Given this list of marker genes SLC4A3, RNF187, LY75, ESYT1, TFAP4 (NCBI Gene Id 7023), FIG4, VEGFA, TARS1, CASP9, CDC5L, TRIO, HLA-DPB1, TCHH, UQCRC2, ITGA3, PLEKHB1, TNFRSF25, TP53BP1, MAGEB2, FKBP1B, CARD10, AHCY, CYB5R3 (NCBI Gene Id 1727), PCNX2, MISP, ECE1, CNOT3, TFE3, CUL4A, SERINC5, HS3ST1, PRR4, ZC3H15, SLC7A5, RIPK2 (NCBI Gene Id 8767), SREBF1, KCNQ1, LPCAT1, DLGAP4, GNAQ, CCHCR1, IRF5, CDH5, CPSF4, ACOT7, ESR1, NACA, PGM1, RBL2 (RB transcriptional corepressor like 2), COX4I1, CDC25A, RBM4B, SOX9, PVALB, CPLX2, HTR1B, AMIGO2, ABCC10, SNU13, CBS, PABPC4, RRP1B, GARS1, YARS1, SUN2 (Sad1 and UNC84 domain containing 2), TM7SF2, KRT16, PCDHB11, HLX, KRT86, TBXAS1, TBX1, UBAC1, RUVBL2, NDUFAF3, TRAPPC12, FOXN3, PTPN9, XIAP, LSM14A, MSMB, EXD2, TK1, ALDH1A2, PPARG, ATG9A, AKAP8L, BDH1, IMPA2, IFT27, SNAPC5, CCK, FOLH1, F7, CCNH, RPS6KA2, SOCS1, SSTR5, ZFYVE26, SLC1A5, RAB33A, SPIDR (scaffold protein involved in DNA repair), ATXN2L, PTPRA, PLA2G5, ENTREP1, LTA4H, MYO1F, GSDME, GPR35, AIMP1, CXCR4, SIX6, ACP5 (NCBI Gene Id 54), TTC22, RNF44, TTC3, TJP1, ARHGEF18, MPST, MDM2, CALB2, DDX51, GRAMD4, TBC1D22A, BAAT, TNFRSF11A, MGAT1, IL5, SHB, CSTF2, CHST7, DCTN2, DCP2, AP1B1, IRF4, GRK2, EIF4H, FYN, UNC5B, BCR, ADH6, PYGL, GATA2, LYPD3, STOML2, PRKRA (NCBI Gene Id 94716), POU2F2, COQ9, DPY19L1, PRDX2, VPS72, TRAF5, PHACTR1, P2RY11, GJB5, HMGB2, HPS1, GOT2, TLE5, SCARB1, H2AZ2, CCDC85B, ARL2, ALDH2 (NCBI Gene Id 217), H2AZ1, GADD45G, FOXO3, CAPN11, PEPD (NCBI Gene Id 84738), ASTN1, EEF1B2, NBAS, UQCRC1, ADNP, SYT17, SYK, FST, MTSS1, SMAD6, RAB32, PLXNB2, EXOSC2, TUFM, DCTN3, USF2, MTMR1, SIVA1, IGFBP1, ASAH1, ADAM15, CUL7, ALOX15, MAGED2, FRAT2, CAMTA2, ZFAND5, GSTT4, ICAM3, here is a description of the gene set: Genes up-regulated in comparison of dendritic cells (DC) exposed to L. donovani versus DCs exposed to M. tuberculosis. species: Homo sapiens Human Gene Set: GSE360_L_DONOVANI_VS_M_TUBERCULOSIS_DC_UP from publication Chaussabel D, Semnani RT, McDowell MA, Sacks D, Sher A, Nutman TB (PMID 12663451) Monocyte-derived dendritic cells (DC) and macrophages (MΦ) generated in vitro from the same individual blood donors were exposed to five different pathogens, and gene expression profiles were assessed by microarray analysis. Responses to Mycobacterium tuberculosis and to phylogenetically distinct protozoan (Leishmania major, L. donovani, Toxoplasma gondii) and helminth (Brugia malayi) parasites were examined, each of which produces chronic infections in humans yet vary considerably in the nature of the immune responses they trigger.